Given this list of marker genes Gnpda2, Nanp, Nans, Gnpda1, Uap1l1, Uap1, Amdhd2, Gnpnat1, Pgm3, Gfpt1, Gfpt2, Gne, here is a description of the gene set: The chemical reactions and pathways resulting in the formation of any amino sugar, sugars containing an amino group in place of a hydroxyl group. studied in species Mus musculus Mouse Gene Set: GOBP_AMINO_SUGAR_BIOSYNTHETIC_PROCESS